The following is a description of a gene set: Acyl chain remodelling of PE Mouse Gene Set: REACTOME_ACYL_CHAIN_REMODELLING_OF_PE species: Mus musculus, and this is the list of marker genes: Pla2g6 (NCBI Gene Id 53357), Pla2g10, Pla2g3, Lpcat4, Pla2g2a, Pla2g4a, Plaat3, Mboat1, Pla2g4d (NCBI Gene Id 78390), Pla2g2f, Mboat2, Lpcat3, Pla2g4e, Pla2g2d, Abhd4, Pla2g4b (phospholipase A2, group IVB (cytosolic)), Pnpla8, Pla2g12a, Pla2g1b, Pla2g4c, Plbd1, Plaat1, Pla2g4f, Pla2g2e, Pla2g5, Plaat5, Pla2r1